The following is a description of a gene set: species: Mus musculus The chemical reactions and pathways resulting in the formation of glycerophospholipids, any derivative of glycerophosphate that contains at least one O-acyl, O-alkyl, or O-alkenyl group attached to the glycerol residue. Mouse Gene Set: GOBP_GLYCEROPHOSPHOLIPID_BIOSYNTHETIC_PROCESS, and this is the list of marker genes: Cwh43, Pip4k2c, Slc30a5, Pla2g6, Ip6k2, Inpp4b, Ptdss1, Tamm41, Crls1, Pip5k1a, Pigo, Pcyt1a, Dgkk, Pigx, Pip5k1c, Pip5kl1, Pik3ca, Pld2, Pgap1, Hycc2, Pigt, Gpat3, Gpaa1, Pigq, Pigyl, Ajuba, Pip4k2b, Efr3b, Itpkb, Pign, Htr2a, Cln3, Hdhd5, Bscl2, Uvrag, Gpam, Dgka, Pik3c2g, Tmem150a, Agpat4 (1-acylglycerol-3-phosphate O-acyltransferase 4), Lpcat1, Ip6k1, Atg14, Pi4kb, Agpat2, Apoa1, Pik3c3, Dgkg, Ip6k3, Fgf7, Piga, Pgap2, Inpp1, Pigu, Itpka, Pcyt1b, Agpat5, Selenoi, Mboat7, Pigk, Dgkz, Pi4ka, Pigc, Dgkq, Chka, Agpat1, Pcyt2, Pgs1, Lpcat2, Bpnt1, Cds2, Chkb (NCBI Gene Id 12651), Impa2, Gpat4, Pigv, Pigp, Mppe1, Vac14, Pik3c2b, Alox15, Pi4k2b, Dgke, Dgkd, Pla2g4c, Slc27a1, Htr2c, Itpkc, Cds1, Htr2b, Far1, Ttc7b, Fabp5, Pip5k1b, Lpcat3, Pdgfb, Abhd5, Pip4k2a, Pigw, Dpm3, Inpp5e, Dhrs7b, Fabp3, Dpm2, Etnk2, Plscr1, Apoa2, Pigh, Pla2g5, Fig4, Pik3cg, Sh3glb1, Atm, Pgap4, Pisd, Pigf, Smg1, Capn2, Pigb, Pik3cb, Pigl, Nr1h4, Pnpla3, Lcat, Tafazzin (tafazzin, phospholipid-lysophospholipid transacylase), Plcg2, Pik3r4, Abhd8, Etnk1, Ptdss2, Pgap3, Acsl3, Dgkb, Dgki, Dpm1, Gpat2, Inppl1, Chpt1, Pld1, Pdgfa, Ptpmt1, Rab38, Pik3r1, Pigm, Pigs, Pigg, Impa1, Pyurf, Pik3cd, Bpnt2, Pla2g4a, Dgkh, Plscr3, Hycc1, Lclat1, Ptprq, Sh3yl1, Cdipt, Pigz, Abhd4, Inpp4a, Agpat3, Cept1, Pik3c2a, Becn1, Pi4k2a, Pemt, Ttc7